Given this list of marker genes Scn2b, Gja1, Scn10a, Gja5, Scn1b, Tbx5, Cacna1g (calcium channel, voltage-dependent, T type, alpha 1G subunit), Scn3b, Scn5a, here is a description of the gene set: species: Mus musculus Mouse Gene Set: GOBP_REGULATION_OF_ATRIAL_CARDIAC_MUSCLE_CELL_MEMBRANE_DEPOLARIZATION Any process that modulates the establishment or extent of a membrane potential in the depolarizing direction away from the resting potential in an atrial cardiomyocyte.